The following is a description of a gene set: Mouse Gene Set: GOBP_ERROR_PRONE_TRANSLESION_SYNTHESIS species: Mus musculus The conversion of DNA-damage induced single-stranded gaps into large molecular weight DNA after replication by using a specialized DNA polymerase or replication complex to insert a defined nucleotide across the lesion. This process does not remove the replication-blocking lesions and causes an increase in the endogenous mutation level. For example, in E. coli, a low fidelity DNA polymerase, pol V, copies lesions that block replication fork progress. This produces mutations specifically targeted to DNA template damage sites, but it can also produce mutations at undamaged sites., and this is the list of marker genes: Polh, Rev3l, Polq (NCBI Gene Id 77782), Pold2, Primpol, Mad2l2, Pole2, Rev1, Polk, Pold3